Given this list of marker genes ATP8B4, AFDN, ERCC6L2, CLOCK, DEK, UPF2, ZNF215, SNAP25, B3GALT4, KRBOX1, TIMELESS, CHRNA5, TRIM6, CD302, ASF1A, BCL2L13, TRPM7 (NCBI Gene Id 54822), GNG12, SWAP70, COL11A1, CDH2, LAPTM4A, PARG, EIF3M, SYAP1, PIF1 (PIF1 5'-to-3' DNA helicase), NHLRC2, UBE2D1, A1CF, PRRC2C, MAP4K4, PCDH11X, N4BP2L1, SLC35F3, RNF38, ZNF124, DYNLL1, ADGRL3, SLC9A6, P2RY14, PHF2, MAPK6, VPS13A, BCLAF3, SPAG16, GCLM, SLC45A2, S100A10, DRD2, ESCO1, EMX2, METAP2, NRP2, FPR3, RASA2, RPF1, POU2F1, ETFRF1, TBP, PLEKHG1, TMEM117, SLC25A23, PLAG1, KCNIP2, SHC1, CTNND2, ILF2, ZNF776, TMEM217, SYT1, C3orf70, HNRNPK, DSTYK, ZNF677 (NCBI Gene Id 342926), SLC27A3, PPP2R5E, ITGB3BP, SERPINB13, ARHGAP21, AKAP11, RAB1A, FNDC3B, LY75-CD302, FAM220A, WNK1, RRAGC, AVPR1A, CCDC120, BACH2, PRRC1, OAF, TNFSF4, JAKMIP3, ADAMTS3, here is a description of the gene set: Human Gene Set: MIR4774_5P studied in species Homo sapiens from publication Chen Y, Wang X (PMID 31504780) Genes predicted to be targets of miRBase v22 microRNA hsa-miR-4774-5p in miRDB v6.0 with MirTarget v4 prediction scores > 80 (high confidence targets).